The following is a description of a gene set: from publication Xie S, Zhou N, Su N, Xiao Z, Wei S, Yang Y, Liu J, Li W, Zhang B (PMID 38577019) Mouse Gene Set: XIE_TRASTUZUMAB_CARDIOTOXICITY_MMU_MIR_345_5P_GENES Abstract: Trastuzumab-induced cardiotoxicity (TIC) is a common and serious disease with abnormal cardiac function. Accumulating evidence has indicated certain non-coding RNAs (ncRNAs), functioning as competing endogenous RNAs (ceRNAs), impacting the progression of cardiovascular diseases. Nonetheless, the specific involvement of ncRNA-mediated ceRNA regulatory mechanisms in TIC remains elusive. The present research aims to comprehensively investigate changes in the expressions of all ncRNA using whole-transcriptome RNA sequencing. The sequencing analysis unveiled significant dysregulation, identifying a total of 43 circular RNAs (circRNAs), 270 long noncoding RNAs (lncRNAs), 12 microRNAs (miRNAs), and 4131 mRNAs in trastuzumab-treated mouse hearts. Subsequently, circRNA-based ceRNA networks consisting of 82 nodes and 91 edges, as well as lncRNA-based ceRNA networks comprising 111 nodes and 112 edges, were constructed. Using the CytoNCA plugin, pivotal genes - miR-31-5p and miR-644-5p - were identified within these networks, exhibiting potential relevance in TIC treatment. Additionally, KEGG and GO analyses were conducted to explore the functional pathways associated with the genes within the ceRNA networks. The outcomes of the predicted ceRNAs and bioinformatics analyses elucidated the plausible involvement of ncRNAs in TIC pathogenesis. This insight contributes to a better understanding of underlying mechanisms and aids in identifying promising targets for effective prevention and treatment strategies. species: Mus musculus, and this is the list of marker genes: Mapre3, Rfc1, Nr6a1, Eif4g3, Ackr2, Sgsm2, Gsk3b, Csmd2, Pdgfrb, Pfkfb3, Ate1, Trip12, Kctd12, Hmg20b, Dnah17, Pxdn, Akap8, Map3k13, Arsg, Cipc, Madd, Atg16l1, Pknox2 (Pbx/knotted 1 homeobox 2), Csdc2, Chid1, Add2, Reep6, Fbxl17, Entr1, Tead1, Tbc1d14, Dlgap4, Nol4l, Brd3, Micu1, Clec5a, 9530068E07Rik, Snta1, Slc6a7, Avpr2, Magi1 (NCBI Gene Id 78178), Clec16a, Cxcl9, Serpina3i, Tsc1 (NCBI Gene Id 64930), Kcnip2, Draxin, Speg, Gabpb2, Unc93b1, Mfsd4b4, Neto2, Plekhm2, Rubcn, Syne1, Pcyt1a, Ncor2, Fam168b, Ntn1, Gm1979, Rgma, Agpat3, Hyou1, Adcyap1r1, Nfx1, Bmp8a, Or5k1, Zkscan1, Espnl, Tmem8b, Pde1b, Kcnj5, Ezh1, Osbpl5, Slc25a25, Traf3, Vsig10, Knop1, Itsn1, Rcc2